Given this list of marker genes Plxna3, Sema3a, Pip5k1c, Tln1, Fyn (NCBI Gene Id 14360), here is a description of the gene set: part of: Semaphorin interactions electronically inferred by orthology from the curated human pathway This event has been computationally inferred from an event that has been demonstrated in another species.<p>The inference is based on the homology mapping from PANTHER. Briefly, reactions for which all involved PhysicalEntities (in input, output and catalyst) have a mapped orthologue/paralogue (for complexes at least 75% of components must have a mapping) are inferred to the other species. studied in species Mus musculus Reactome Pathway: SEMA3A-Plexin repulsion signaling by inhibiting Integrin adhesion